The following is a description of a gene set: species: Homo sapiens Catalysis of the reaction: adenosine + H2O = inosine + NH3. Human Gene Set: GOMF_ADENOSINE_DEAMINASE_ACTIVITY, and this is the list of marker genes: ADAD1, ADAT3, ADAT2, ADAT1 (NCBI Gene Id 23536), MAPDA, ADAD2, ADA, ADA2, ADARB2, ADARB1, LACC1, ADAR